Given this list of marker genes M, here is a description of the gene set: studied in species Homo sapiens Protein M, part of which is N-glycosylated, accumulates in the Golgi complex and recruits Spike protein to the sites of virus assembly and budding in the ERGIC. Reactome Pathway: Maturation of protein M_9683612 part of: Translation of Structural Proteins